The following is a description of a gene set: Mouse Gene Set: GOBP_REGULATION_OF_RHO_PROTEIN_SIGNAL_TRANSDUCTION Any process that modulates the frequency, rate or extent of Rho protein signal transduction. species: Mus musculus, and this is the list of marker genes: Fxr1, Dock10, Arhgdib, Stard8, Itgb1, Adra1b, Dock8, Cdh2, Cul3, Prag1, Itga3, Ripor2, Kctd10, Dock9, Arhgef28, Rit2, Lpar1, Erbb2, Gpr55, Fermt2, Rasip1, Cdc42se2, Ophn1, Abl2, Arhgap35, Scai, Apoc3, Mcf2l, Eps8l3, Abca1, Adra1a, Tagap, Arhgap20, Robo1, Nrp1, Kank1, Gpr4, Eps8l2, Adgrg1, Ngfr, Arhgef18 (Rho/Rac guanine nucleotide exchange factor 18), Cdc42se1, Dock11, F11r, Abra, Kank2, Myoc, F2r, Eps8l1, Ralbp1, Dlc1, Arhgef3 (NCBI Gene Id 71704), Ripor1, Stard13, Arhgef2, Csnk1a1, Heg1, Dock6, Rtn4r, Myo9b (myosin IXb), Apoe, Sema4d, Bcr, Arhgap42, Flot1, Stmn1, Pdgfrb (platelet derived growth factor receptor, beta polypeptide), Arhgdia, Akap13, Arrb1, Tns3, Synpo2l, Plxnb1, Met, Dock7, Tnfaip1, Lpar2, Eps8, Ccdc125, Apoa1 (apolipoprotein A-I), Col3a1, F2rl1, Flcn, Kctd13, Abl1, Net1 (neuroepithelial cell transforming gene 1), Bcl6